Given this list of marker genes PLN, ADRA1A, ZC3H12A, TAC1, RNLS, ADCY10, SRI, PDE4D, MIR208A, GRK2, NPFF, SPTBN4, FKBP1B, APP, AGTR2, TNF, BIN1, GJD3, SPX, ATP1A2, MIR30E, ATP1A1, ATP2A2, PIK3CG, AGER, MIR26A1, here is a description of the gene set: Any process that stops, prevents or reduces the frequency, rate or extent of blood circulation. studied in species Homo sapiens Human Gene Set: GOBP_NEGATIVE_REGULATION_OF_BLOOD_CIRCULATION